The following is a description of a gene set: Human Gene Set: GOBP_MEMBRANE_LIPID_CATABOLIC_PROCESS species: Homo sapiens The chemical reactions and pathways resulting in the breakdown of membrane lipids, any lipid found in or associated with a biological membrane., and this is the list of marker genes: SMPD4, CEL, SMPD2, ACER3, ENPP7, NAGA, NEU3, SMPD1, M6PR, HEXA, NEU2, SGPP1, SUMF1, MIR16-1, NEU1, GBA1, ALDH3B1, ZPBP2, PPT1, FUCA1, NEU4, ACER1, GM2A, PNLIPRP2, SMPD3, ENPP2, GBA2, ETNPPL, ASAH2, CYP1B1, LCT, MGST2, SGPL1, GLB1, SMPDL3B, PLPP3 (phospholipid phosphatase 3), MIR127, PLPP1, GBA3, SCARB2, MIR195, PRKCD, PLPP2, HEXB, SPHK1, ALDH3B2, SGPP2, GALC, ASAH2B, VPS54, ACER2, ASAH1, GLA (NCBI Gene Id 2717), SMPDL3A